Given this list of marker genes Tasl, Ikbkb, Irf5, here is a description of the gene set: part of: Toll Like Receptor 7/8 (TLR7/8) Cascade; Toll Like Receptor 9 (TLR9) Cascade Reactome Pathway: SLC15A4:TASL-dependent IRF5 activation species: Mus musculus electronically inferred by orthology from the curated human pathway This event has been computationally inferred from an event that has been demonstrated in another species.<p>The inference is based on the homology mapping from PANTHER. Briefly, reactions for which all involved PhysicalEntities (in input, output and catalyst) have a mapped orthologue/paralogue (for complexes at least 75% of components must have a mapping) are inferred to the other species.